Given this list of marker genes Npr2, Abl1, Flrt3, Csf1r, Fmn1, Fgf13, Edn2, Syt4, Rufy3, Tnr, Fxn, Rab21, Rnd2, Fgf10, Cpne1, Mapt, Bcan, Hnf1b, Sema4d, Srf, Tiam1, Iqgap1, Adprhl1, Cadm1, Trim28, Prkcz, Wdr36, Slc12a2, Wnt3a, Epb41l5, Lhx1, Slit3, Gsk3b, Bmpr2, Postn, Jade2, C9orf72, Prickle1, Sh3gl2, Prkg1, Tmem108, Pou4f3, Sema6c, Twf2, Epha7, Wnt3, Spag6, Ifrd1, Dclk1, Wnt11, Mul1, Sema4f (sema domain, immunoglobulin domain (Ig), TM domain, and short cytoplasmic domain), Ulk1, Cttn, Tgfbr2, Zeb2, Spry2, Syt3, Ulk2, Afdn, Nkd1, St8sia2, Mecp2, Ext1, Adcy10, Rims1, Mst1, Eif2b2, Pak6, Slit2, Pthlh, Sh3glb1 (SH3-domain GRB2-like B1 (endophilin)), Ep300, Disc1, Tsc22d4, Spag9, Auts2, Ptk7, Rnf157, Map1b, Yap1, Aurka, Alcam, Arhgap32, Cdh1 (NCBI Gene Id 12550), Spart (spartin), Pafah1b1, Fgfr2, Spag6l, Sfrp2, Sfrp1, Tbx2, Plaa, Itsn2, Barhl2, Cdkl5, Notch1, Rtn4r (reticulon 4 receptor), Six1, Reg1, Ryk, Draxin, Ccr5, Impact, Efna5, Nrn1l, Edn1, Nlgn3, Apoe, Mgll, Lzts2, Zfyve27, Kdm1a, Unc13a, Cfl1, Ttl, Garem2, Cdkl3, Lrp1 (low density lipoprotein receptor-related protein 1), Rtn4, Eif2ak4, Flrt1, Cpne5, Dnm2, Emx1, Clasp2, Smo, Wnt7b, Bmp4, Crabp2, Nedd4l, Nat8f3, Dbnl, D130043K22Rik, Ppp2r3a, Hoxd13, Rnf6, Itga4, Sema3f, Lamb2, Vcl, Macf1, Sall1, Cacng7, Vangl2, Bin3, Nfix, Tfap2c, Slc23a2, Dvl1, Lrp6, Cyfip1, Islr2, Hdac6, Dip2b, Slc39a12, Nkx6-1, Ostn, Sox9, Ahr (NCBI Gene Id 193333), Kif26b, Usp9x, Slc9a6, Ist1, Picalm, Six4, Mag, Cst5, Dscam, Wnt5a, Tgfb1, Esr1, Atg16l1, Nrp1, Anapc2, Areg, Sema3g, Rasal1, Adnp, Itgb1, Mt3, Limk1, Arhgap4, Dbn1, Nrp2, Pou4f2, Zfp568, Lpar3, L1cam, Sema5b, Fn1, Olfm1, Tnfrsf12a, Spry1, Bcl11a, Edn3, Ntrk3, Ctnnb1, Spg21, Spg11, Tnn, Rpl4, Cobl, Sfrp5, Fstl4, Trim46, Wasf1, Rgma, Mir124a-2, Shtn1, Cxcr4, Bdnf, Myo5b (myosin VB), Llph, Cyfip2, Sema7a, Rdh10, Nin (NCBI Gene Id 73198), Ccl11, Cxcl12, Hnrnpk, Plxna1, Syt17, Pten, Ssna1, S100b, Ntn1, Slitrk1, Pum2, Vegfa, Kdm5b (lysine demethylase 5B), Trpc5, Tnc, Raph1, Ngf, Slit1, Fgf1, Syt2, Ptprs, Plxna4, Prkn, Rarg, Ilk, Mesp1, Sin3a, Map2, Robo1, Omg, Rims2, Plxna3, Sema3a, Cdh4, Ednra, Cpne9, Septin7, Eif4g2, Dcx, Gdi1, Sema5a, Cd2ap, Nrn1, Lhx2, Map3k13, Actr3, Cpne6, Tmtc3, Golga4, Syt1, Clstn3, Ndel1, Med1, Megf8, Mir124a-1, Stk11, S1pr1, Sema6d (sema domain, transmembrane domain (TM), and cytoplasmic domain, (semaphorin) 6D), Med12 (NCBI Gene Id 59024), Sirt6, Smurf1, Pak1, Csf1, Trpv2, Shh (NCBI Gene Id 20423), Ndn, Ddr1, Cdk5, App, Ttc3, here is a description of the gene set: species: Mus musculus Mouse Gene Set: GOBP_DEVELOPMENTAL_GROWTH_INVOLVED_IN_MORPHOGENESIS The increase in size or mass of an anatomical structure that contributes to the structure attaining its shape.